Given this list of marker genes Inpp5d, Cdk6, Apcs, Myc, Zbtb46, Bmyc, Hoxa7, Gpr68, here is a description of the gene set: Mouse Gene Set: GOBP_NEGATIVE_REGULATION_OF_MONOCYTE_DIFFERENTIATION species: Mus musculus Any process that stops, prevents, or reduces the frequency, rate or extent of monocyte differentiation.